Given this list of marker genes CXCL9, NAA50, TBC1D12, TNFAIP8, SVOP, SMC2, CTDSPL2, ABHD6, TAPT1, TRPC3, FMN1 (NCBI Gene Id 649014), ZKSCAN4, PSMD11, RAPH1, RRAS (NCBI Gene Id 6237), EMC7, AHSA2P, PCDH15, PNMA8A, SRGAP1, ZKSCAN3, AKT3, CIT, EYS, TBC1D8B, DCAF12, DCAF7, TENM3, PCDH10, CD36, LBH, SMARCA4, CELSR2, SOHLH2, THAP9, HPS6, SORL1, ADGRG6, MRPL22, LYSMD4, KRTAP4-7, LGALSL, AEBP2, MMP1, LIPA, SERPINB8, CCDC169-SOHLH2, DGKG, AGBL3, GRIK2 (NCBI Gene Id 2898), SLC38A1, ZFR2, JARID2, PRICKLE2 (prickle planar cell polarity protein 2), DYNC2H1, B3GNT5, YWHAE, PHLPP1, DDX23, GLCE, BEND4, STRN, SNAP91, SDC2, F2R, KANK2, RAB33B, VWA5B2, UBP1 (NCBI Gene Id 7342), KDM5B, MEIOC, SPOCK1, TSPAN12, CDC42SE2, ZFX, RBM7, MYO3B, ZEB2, RICTOR, ZFP36L1, WDR1, NEK6, PTPN5, GPR155, DSG2, GPR180, GBP5, TBXAS1, DYDC2, HYCC2, AKAP6, GSPT2, PDE9A, BCKDHB, CECR2, PAIP2, TMEM200A, WEE1, ASXL3, MMP24, ZNF451, HAL, DCBLD2, RNF11, RPA1, EXTL2, MBNL2, FBXO33, CREBL2, CBFA2T3, TTBK1 (NCBI Gene Id 84630), PLEKHA5, GREM1, MYO1D, AFF2, ATP5MC3, DGKI, FAM43B, CHEK2, LZTR1, UBE2Z, ZNF211, RRAGD, RETREG3, RRAGC, KAT7, CALB1, UBXN4, GABRA6, GABRB2, OSGIN2, CYRIA, here is a description of the gene set: Genes predicted to be targets of miRBase v22 microRNA hsa-miR-5190 in miRDB v6.0 with MirTarget v4 prediction scores > 80 (high confidence targets). Human Gene Set: MIR5190 from publication Chen Y, Wang X (PMID 31504780) species: Homo sapiens